Given this list of marker genes PSPH, GLS, SLC1A5, SLC7A11, PSAT1, SLC2A1, PHGDH, here is a description of the gene set: species: Homo sapiens Amino acid metabolism in triple-negative breast cancer cells Human Gene Set: WP_AMINO_ACID_METABOLISM_IN_TRIPLENEGATIVE_BREAST_CANCER_CELLS